The following is a description of a gene set: Human Gene Set: GOBP_INTRINSIC_APOPTOTIC_SIGNALING_PATHWAY_BY_P53_CLASS_MEDIATOR The series of molecular signals in which an intracellular signal is conveyed to trigger the apoptotic death of a cell. The pathway is induced by the cell cycle regulator phosphoprotein p53, or an equivalent protein, and ends when the execution phase of apoptosis is triggered. species: Homo sapiens, and this is the list of marker genes: TAF9, MIR21, PERP, URI1, CDKN1A, RRM2B (NCBI Gene Id 50484), PHLDA3, CD44, PML, TP53, TP73, SNW1, E2F2, HINT1, MSH2, MUC1, TAF9B, CASP6, BCL2, BRCA2, EIF5A, POU4F1, BCL2L12, RPL26, RRP8, MYC, TMEM109, FHIT, BCL3, PPP2R5C (NCBI Gene Id 63377), TP53BP2, WWOX, NUPR1, HIPK1, DDX5 (NCBI Gene Id 1655), MIR186, E2F1, MYBBP1A, TP63, ARMC10, RPS27L, HIPK2, CHEK2, JMY, IFI16, USP28, AEN, ZNF385A, ELL3, BDKRB2, TOPORS, ERCC2 (ERCC excision repair 2, TFIIH core complex helicase subunit), PYCARD, POU4F2, HNRNPK, BAG6, PTTG1IP, EP300, PMAIP1, CD74, KDM1A, BOK, PPP1R13B, DDIT4, STK11, TIFAB, ATAD5, ING2, UBB, MDM2 (NCBI Gene Id 84825), MARCHF7, CDIP1, BAX, RRN3, SIRT1, MIF, PRKN, SHISA5, BBC3 (BCL2 binding component 3), PDK2, MSX1, USP15, TP53BP1, TRIAP1 (TP53 regulated inhibitor of apoptosis 1), RPS7, DYRK2, ZNF385B, EDA2R